Given this list of marker genes POLR2K, POLR2L, ESRP2, POLR2E, NCBP2, HNRNPA1, FGFR2, HNRNPM, POLR2G, POLR2D, HNRNPH1, PTBP1, TIAL1, POLR2C, POLR2H, POLR2F, POLR2A (RNA polymerase II subunit A), GTF2F1, TIA1, RBFOX2, HNRNPF, POLR2J, GTF2F2, NCBP1, POLR2I, ESRP1, POLR2B, here is a description of the gene set: species: Homo sapiens FGFR2 alternative splicing Human Gene Set: REACTOME_FGFR2_ALTERNATIVE_SPLICING